The following is a description of a gene set: species: Mus musculus Mouse Gene Set: chr13B2, and this is the list of marker genes: 4930486L24Rik, Gm19866, Cts3, Ctsll3, 4930528D03Rik, Ctsm, Gm10312, Gm6474, Gm35333, Isca1, BC051665, Tut7, 4930455M05Rik, Spata31d1a, Ctsj, Golm1, Ctla2b, Spata31d1d, Etohd2, Gm10779, Tpbpa, Cts8, Gm34721, Ctsr, Spata31d1e, Gm34788, Naa35, Gm18064, Gas1, A930015P04Rik, Agtpbp1, Ctla2a, 4921517D22Rik, Spata31d1b, A530001N23Rik, Gm40975, Gm34672, Gm40976, Gm34961, A530065N20Rik, Gm5664, Dapk1, Cts6, Cts8-ps, Tpbpb, Cts7-ps, Ctsq, Ctsm-ps, Gm5084, Cts7, Gm7622